Given this list of marker genes SYNPO, SMG5, C5AR1, INTS12, ATF6, SELENOH, NECTIN1, LINC00963, SCARNA2, FAM200A, COPS2, SLC24A1, EFNA3, PGK1, CSTPP1, SMARCD2 (SWI/SNF related, matrix associated, actin dependent regulator of chromatin, subfamily d, member 2), FRMD3, SEMA7A, CCNL1, TPI1P2, EIF3G, FIRRM, DHX30, RASGEF1B, FANCA, TMEM69, ZNF461 (NCBI Gene Id 92283), NBPF12, RHOT2, ADRA1A, TARBP2, PLEKHG4, NCBP2AS2, POLR2C, ZNF425 (NCBI Gene Id 347684), SH3GL1, SELPLG, POM121L2, RPL27, VTRNA1-3, ZNF268, ZSCAN16-AS1, KDM1A, DSTYK, FABP5P3, PRECSIT, KRAS, SNORD54, CRADD, KLF15 (NCBI Gene Id 28999), OGFOD2, TESK2, ABCB9, ZNF408, NOXA1, SUDS3, NKIRAS2, PSMD3, MRPS30-DT, SUCLA2, GCHFR, PIGC, CTNNB1, CORO2A, SNX18, POGLUT3, NME1, HAUS5, SMIM10, TJP3, CALM1, METTL15, AQR, GLIPR1L1, CENPW, POGK, FNIP2, FZD1, FRA10AC1, YWHAE, ARHGAP1, IFT46, GTPBP2, CARD8, DHX16, CCNC, DIAPH1, RBM45, THSD4, ZNF391, SPECC1P1, RBBP5, DDX55, CDKN2C, ZNF213-AS1, TBC1D13, EIF1AD, MAP4, TBCD, SAMD11, ARMH3, TRMT13, NUP62, MARK4, CAPS2, UBE2H-DT, GABPB2, DUS1L, FLNA, RBM15-AS1, MRPL44, CAV1, BMS1P4-AGAP5, PDCD6, WARS1, ZNF704, PFKFB3-AS1, VPS72, YJU2, NSFL1C, TOR1AIP1, POLR1HASP (POLR1H antisense, pseudogene), TTC4, WDR11, ZNF45, GEMIN7, TIPRL, S100A2, DRG2, DCDC1, BANF1, DRAP1, HAUS5-DT (HAUS5 divergent transcript), BCRP2, ZSCAN9, ADAP2, RPL18, PARP6, TRMT2A, ITGB3BP, FRS3, CT62, RPS19, SSBP1, CIPC, GTF3C3, MIR4674, PDXDC1, CFAP410, ASNS, COG2, NUDT19, POLDIP2, ABCA15P, HUS1, RINT1, NOTCH1, EIF3F, TAF1C, SLC1A4, LINC01411, C6orf52, PTOV1, FBXW7, TMC7, GUSBP1, ZNF783, ZNF205, WDR31, CSNK1D, TIMM29 (NCBI Gene Id 90580), ZNF131, INO80B, CPSF4, IER5, RANBP1, TSFM, UBA52, PHYHIP, IGHMBP2, AP3S2, IL4I1, CCDC65, DNAJC24, TOP3B, DPY19L4, NCOA7, ABCB10, CIRBP, TMEM242, BMF, LZIC, MRPL58, TMEM126B, C17orf75, PPP2CB, RHBDF1, GSE1, RPS17, CACHD1, SOAT1 (sterol O-acyltransferase 1), ADAR, GYS1, NECTIN1-DT, SLX9, ZMIZ1, SMU1, FKBP4, RNA5SP283, IRF9, DCP1A, PHLDA3, ENSG00000232995, GBA1, PIM1, NDUFB7, MCC, ZNF787, CDC42SE1, ALKBH3, RN7SL521P, WDR25, DDX11L5, FAM86FP, SETD5, METTL18, HEATR1, TBX18, COMMD2, RNU7-27P, ALG5, GARS1, YIPF2, NCBP3, RNU6-821P, ST7, PRELID3A (PRELI domain containing 3A), SHISA2, BMI1, RNVU1-30, PIGL, LUCAT1, HMGN4, HNRNPF, RNU6-433P, TUBA1A, CPNE8, MRPS31P4, TARS2, ZER1, ALG10, IPO13, DPP9, SDHAF3, TMEM214, MTF2, TMEM199, RETSAT, TSC22D4, PPIP5K2, LINC00431, VPS25, CASTOR3P, SLC1A5, MANEAL, RPS27P30, COX16, MBTPS2, TMEM141, ATXN1-AS1, RERE, MRPS31P5, ZNF212, ABHD13 (abhydrolase domain containing 13), THOC5, TMEM147, PLEKHG2, ACVR1B, AHCYL1, PCAT19, TBL1X, CERNA3, MALSU1, PARL, LINC02453, OLFM2, ELMOD3, DLG2, URB2, LINC01023, GALK2, MED23, NUS1 (NUS1 dehydrodolichyl diphosphate synthase subunit), PPP6R3, PIH1D2, UBE2H, DDX46, BCAT2, MRPS33, CTDSP2, STRC, CRBN, ATF6-DT, LRRC59, UCHL5, SCRIB, NDUFAF4P1, ZNF767P, PCDHAC1, STUM, P4HTM, LINC00680, LAMP1, NSD2, RNU6-1228P, CLTB, DMAP1, PAK1, BBS1 (NCBI Gene Id 79702), POR, SEC13, PAK1IP1, MAN2C1, PEX3, RPS27, ENSG00000237101, TOMM22, INTS14, PDSS2, VWA8-AS1, RNY1, TPGS1, RNY3, ENSG00000223343, SERP1, BAX, IFT20, GTF2H4, COPS5, PPIL4, SEC22B, CITED2, ZCCHC4, CREBL2, ENSG00000247416, CFAP298, PTOV1-AS1, MRPS10, OGT, LDHA, TMEM41A, MLEC, TAFA2, RCOR1, PRR14, DRAIC, ALDOA, TUBB8P1, LINC01547 (long intergenic non-protein coding RNA 1547), GNG12-AS1, GADD45A, FAM227B, HOXB9, FANCD2, ZNF280D, TM4SF19, NUDT19-DT, PVALB, FUT1, TMEM182, RPSAP31, ASIC1, NOSIP, WDR83, GPBP1L1, TMEM242-DT, KCTD5, CCDC144BP, TVP23B, IKBKG, CRYBG1, REXO4, MED4, LMBR1, PRKCE, STOML1, ZNF609, RPS20, ATP2B4, SLC39A13, SLC5A3, PPIL3, WIZ, DNAJC2, ZNF398, RBM28, NSA2, GSTCD, VWA7, H4C8, ADAT2, PTGES3P3, EDC4, LAMTOR5-AS1, R3HCC1, ADPRHL1, MRPS30, B4GAT1-DT, NME1-NME2, SMG1P3, TAP2, TCF12, COQ3, CYP2E1, WEE2-AS1, DLC1, INTS1, FILIP1, ARL8B, SMG7-AS1, SLC44A1, MTMR3, MYCBP2-AS1, PRKAB2, FOXJ3, TNFAIP1, RPL38, TEFM, MDM2, PTK7, SLC33A1, SNHG12, KIFBP, LASP1, EIF2D, POLR3B, TM4SF19-DYNLT2B, EXD3, WTIP, INTS5, CFAP74, GIN1, CNOT4, GNAL, USP6NL, MIR3190, ERI1, GDE1, DTWD1, SLC36A1, ALDH1A2, RANBP9, WDR24, LGALS3BP, CILK1, SMIM2-AS1, SLC13A4 (solute carrier family 13 member 4), TMEM222, STX18, GTF2IP12, HNRNPD, RMND1, VWA8, MTOR, FAF1, POLR1F, LRRC37A3, LNCTSI, TEDC1, SUB1, ALKBH3-AS1, GPR107, PFKFB3, NDUFAF1, WFDC21P, SCYL1, MDC1, GHET1, UBA2, AGK-DT, NECAP2, NIF3L1, PDXK, LINC02029, EFCAB7, INO80C, WDR62, STEEP1, NMNAT1, RO60, MRPL27, DMAC2L, ENPP3, LIG4, TMEM147-AS1, PKM, NFKBIL1, SPAG5, IPO4, LRRC4, CCNY, STAT3, RNF220, GNB2, TRAM2, DDX50, PRDX1, MIR99AHG, STX6, AARS2, AGK, ATP5MJ, ELOA-AS1 (NCBI Gene Id 100509187), ENSG00000282849, DPY19L1, MRPS31, CIT, COX6CP7, MRPL12, CCAR2, WDR83OS, TTC23, SRXN1, SEPTIN7P14, SLC26A11, OXCT1, HERC5, PYCR2, TADA1, MAD1L1, TGFBI, ARID2, HCP5, ALG10B, SYTL2, RPL32P27, GLUD1P3, RBM17, SLC35E2A, ATP6V1G2, MIR762HG, GUSBP2, BRF2, NDUFC2, TAF5L, LAMTOR5, SLC39A3, SNORA13, GARS1-DT, KMT2C, ANGEL1, MAST4, C1orf105, OSTM1, SMG7, RPP14, ARHGAP22, ARID1A, TMEM79, NUP133-DT, LSG1, ZNF165, BMS1P4, ENAH, EMC1-AS1, C11orf68, EML2, WDR11-DT, VARS2, YARS1, CPE, COPS4, LYRM2, MRPL3, KCTD8, DZIP1L, IFI44L, USP15, SNRNP35, JPX, GTF3C5, CCDC159, B4GAT1, STK40, NR1H3, SF3A3, NXF1, ZNF350, OTUD7B (OTU deubiquitinase 7B), ARF5, OLFM1, CBX4, NUPR1, LINC02093, CSRNP2, APBB3, PPP4C, CLN3, ITGA7, CFAP298-TCP10L, BMS1, HEXA-AS1, FEM1B, BCAR3-AS1, S100PBP, C12orf76, TCEANC, SASS6, NCAM1, VKORC1L1, AURKAIP1, FRG1HP, PRRG2, DOCK7, INTS10, SDK1, NUF2, PEMT, IFRD1, ATF5, VTRNA1-1, ZBTB40, SNORD114-24, CSPP1, PXMP2 (peroxisomal membrane protein 2), CCDC97, MCF2L, ACP2, KLHL20, NEDD1, CDKN2AIPNL, ELAVL2, EXOSC3, CCNT2-AS1, IGF1R, IQSEC1, ANKRD40, VPS51, DOCK7-DT, RGS7, TOMM22-DT, ZSCAN16, SPHK2, STX18-AS1, MESD, TMEM101, TARBP1, PCBP2, FLT3LG, LINC01556, RWDD3, TCTN3, LARS2, BRINP2, RPA3, NR1H2, TFEB, CUTA, LSM11, ARMT1, CENPU, METTL9, GFI1, POLR1H, IPP, CBX3P4, SGPL1, LINC02739, PXK, UBTF, ECI1, PRPF18, FAM133B (family with sequence similarity 133 member B), SEMA6A, TMED2, RNU11 (RNA, U11 small nuclear), NBPF19 (NCBI Gene Id 101060226), HTD2, ARHGEF12, EME1, TMEM128, ZNF629, MRPS14, NUP133, MIR4519, TRAM2-AS1 (NCBI Gene Id 401264), TRDMT1, SLC9A1, FREM2, XPNPEP1, SMIM12, RSAD1, GFM2, RBPJ, MSANTD3, NUDT9, LTBP4, ISLR2, FGF21, TLCD3B, SHF, TOR1A, MRPL1, POLR3E, INO80B-WBP1, NCBP2, RPL41, MED9, MAML3, SNORA16A, IL1RAP, BRD2, CIAO3, COQ8B, BAZ2A (NCBI Gene Id 23525), FAM98B, BANP, LURAP1L-AS1, GCLC, MEF2C, MAP7-AS1, HSP90AA1, KDELR1, RPL29, LRP3, GOLGA3, IFT56, VPS4A, MSTO1, CFDP1, RGS5, CASZ1, PSMC2, RPTOR (NCBI Gene Id 654218), SMG8, SUZ12P1 (SUZ12 pseudogene 1), POLR2J4, RBM15, PIPOX, SLC7A5P2, HLA-DQA1, HIRA, TRAJ7, LAMP2, NOP16, ERGIC2, KRR1 (NCBI Gene Id 11103), PLEKHM1 (pleckstrin homology and RUN domain containing M1), PCAT6 (NCBI Gene Id 100506696), MIR4500HG, EPB41L4A-AS1 (NCBI Gene Id 114915), LINC02366, GLIPR1L2, HEXA, MICA, ENSG00000267024, RPS26, TBC1D1, NFE2L2, TAF4, SYNPO2, SNHG11, TNPO3, TP53BP2, POLE, LINC02768, CIDECP1, APBA1, RNU6-554P, RN7SL346P, WDR59, PTPRG, RWDD3-DT, MRPL21, SPART, LINC00240, KBTBD3, RRP15, LINC01010, LINC02288, BNIP1, PSMB7, ITPRIP, ISG20, BCL6, PHYH, FUT10, TTC33, DZIP1, UTP3, NDUFC2-KCTD14, PTCD1, USP30, NKAPD1, SLC35A4, RHEX, TMEM170A, NALT1, HOXB5, ATP6V1G2-DDX39B, here is a description of the gene set: studied in species Homo sapiens Human Gene Set: ZNF660_TARGET_GENES from publication Yevshin I, Sharipov R, Kolmykov S, Kondrakhin Y, Kolpakov F (PMID 30445619) Genes containing one or more binding sites for (ZNF660) in their promoter regions (TSS -1000,+100 bp) as identified by GTRD version 20.06 ChIP-seq harmonization.